Given this list of marker genes LINC02427, ADAM20P3, WWC2, SORBS2, LINC02492, CENPU, MLLT10P2, DCTD (NCBI Gene Id 1635), CLDN22, STOX2, ENSG00000251310, TRAPPC11, FLJ38576, ENSG00000286821, FAM149A, CFAP97, MIR3945HG, KLKB1, DUX4L5, RNA5SP175, RPL7AP27, LINC01596, SLC25A5P6, CYP4V2, ANKRD37 (ankyrin repeat domain 37), PDLIM3, DUX4L8, DUX4L1, MIR3945, RNU6-335P, TRIML2, RPSAP70, RNU6-1055P, LINC02515, ING2, FRG1-DT, TRPC6P7, ACSL1, DUX4L6, RNU7-192P, COPS3P1, SLC25A4, ENSG00000307445, HSP90AA4P, DUX4L2, AGGF1P1, LINC02434, PRIMPOL, ENSG00000286641, F11-AS1, RNU4-64P, RNU6-1053P, DUX4L4, TLR3, LINC02365, LINC02363, LINC02374, TRIML1, CLUHP4, SNX25, TUBB7P, LRP2BP, LTO1P1, SLED1, RNU6-173P, LINC02436, RNU1-51P, ENSG00000250626, WWC2-AS1, IRF2-DT, MIR4455, CASP3, RNU2-34P, DUX4L3, ENSG00000301147, RWDD4, FAT1, FBLP1, RN7SKP67, SNORD79, RN7SL28P, FRG1, LINC02508, LINC01262, RNA5SP174, HELT, MRPS36P2, ZFP42, ING2-DT, LINC01060 (long intergenic non-protein coding RNA 1060), DUX4, F11, DBET, ENSG00000295628, RPL6P16, RPL23AP84, LINC02437, CLDN24, MTNR1A, CIBAR1P2, UFSP2, CCDC110, ICE2P1, CDKN2AIP, ENSG00000283383, SORBS2-AS1, ENSG00000294559, DUX4L7, RNU6-479P, WWC2-AS2, RARRES2P4, LINC02362, LINC01093, IRF2, CFAP96, MYL12BP2, ENSG00000235149, ENPP6 (NCBI Gene Id 133121), ENSG00000249642, LINC02514, VTI1BP2, FRG2, DUX4L9, here is a description of the gene set: studied in species Homo sapiens Human Gene Set: chr4q35